The following is a description of a gene set: species: Homo sapiens Genes having at least one occurrence of the motif TTAAGTRSTT in the regions spanning 4 kb centered on their transcription starting sites. This matches the NKX2-2 transcription factor binding site V$NKX22_01 (v7.4 TRANSFAC). Human Gene Set: NKX22_01, and this is the list of marker genes: PHOX2B, ADGRB3, PDZRN4, RABL6, CACNA1C, DMD, MRPS7, HOXA3, C6orf62, ASB4, SYT4, DMRTA1, TSGA10, CSRNP3 (cysteine and serine rich nuclear protein 3), WNT8B, NRP2, CHRM1, CYTH3, SOHLH2, HOXD13, CFAP161 (cilia and flagella associated protein 161), ELAVL2, POLA1, SAP30L, RRAGB, GGA3, ITPR1, SDF2L1, INSRR, ZHX2, RIT2, C16orf74, LMO4, HPN, TFAP2D, TMEM185A, MIR137HG, TRA2A, NSD1, CLVS1, FGF20, PPP2R3C, CCDC126, FNBP1L, CD36, CAPZA3, PLRG1, PDYN, CWC15 (NCBI Gene Id 51503), PLCZ1 (NCBI Gene Id 89869), GPRIN3, NLGN2 (neuroligin 2), BMP5, SULT2A1, SH3KBP1, PMCH, MYL1, PITPNM2, ALB, FBXW7, EDC4, AEBP2, CITED4, EPHB2, CRK, NFIX, ARMCX2, SCNN1G, GLA, NOL4L, HOXC4, COQ7, THRA, NAT8L, CDKN2C, RBBP7, NDP, TTC9C, FOXP2, SRPK2, CLDND1, NKX2-2, NTRK1, TIAM1, LHX5, ZFYVE9, TTYH1, TBRG1, CDK11B, WNT7A, SRSF6, CAVIN2, GIGYF2, IFT43, CDK11A, HOXB7, SEL1L, PRAF2, PIP4K2C, EPB41, KCNJ13, SPON1, KDM4D, IL12B, FGF16, DST, STAT5B, SCARF2, NDFIP1, NIPBL, CTNNA3, STARD8, MAPK6, KIF13A, ZRANB1, R3HDM2, ESR1, C14orf119, CPEB4, UBR3, GSC, KRT36, FZD2, ZNF407, HPSE2, LHFPL1, SALL3, DENND6A, SLC44A1, GOLGA1 (golgin A1), PIK3R1, ASIC4, MYH2, KEL, PBK, DLC1, FOXP1, WWC1, NUAK1, ZNF423, ESRRG, ZBTB18, SLIT3, STAG2, PRDM12, GSE1, NEDD4, NOTCH1, MANEAL, TBR1, PRDM13, ETV5, SYTL2, RELCH, NEO1, NFIA, SMOC2, MDFIC, TRAF3IP2, EGR2 (NCBI Gene Id 1959), RGS3, LRRC8A, PCDH17, CALHM5, LUC7L3, BHLHE41, LINC01597, CCT7, HNRNPH2, LRRTM1, HNRNPA0, ARPC1A, HHEX, PRADC1, GATA6, MYL3, JMJD1C, NKX2-8, OTP, ACIN1, CCDC92, PPM1E, TMEM126B, ZBTB20, ADGRG6, GSK3B, SCHIP1 (NCBI Gene Id 29970), LINC00649 (NCBI Gene Id 400863), ZNF654, DLG2, PHF21A, GLRA3, BAMBI